The following is a description of a gene set: Any process that modulates the frequency, rate or extent of the directed movement of charged atoms or small charged molecules into, out of or within a cell, or between cells, by means of some agent such as a transporter or pore. studied in species Homo sapiens Human Gene Set: GOBP_REGULATION_OF_MONOATOMIC_ION_TRANSPORT, and this is the list of marker genes: CRBN (NCBI Gene Id 51185), G6PD, TACR2, CALHM1, GRP, P2RX2, CD4, ATP1A2, RGS9, VDAC1, EFHB (EF-hand domain family member B), PDPK1, EPO, STIMATE, ATP8B1, PPP3R1, SLC31A2, LIME1, MLLT6, AGT, SCN2B (sodium voltage-gated channel beta subunit 2), HOMER3 (homer scaffold protein 3), MYLK, CACNG6, KCNJ10, TESC, NTSR1, SLMAP, F2RL3, BCL2, TRPC3, MIR133A1, UTRN, SPTBN4, SCN5A, AKAP5, KCNS1, STC2 (NCBI Gene Id 8614), CACNB4, DPP6, SCN10A, LCN2, AFG3L2, ATP1B3, MS4A1, TREM2, PHB2, WNK3, P2RX3 (NCBI Gene Id 5024), TRPC6, ADCYAP1R1, RAB11B, GRIN2C, KCNAB2, KCNJ15, HOMER1, CD19, RGS4, KCNN2, CRHR1, CASK, KCNJ9, ADORA2A, PACSIN3, NIPSNAP2, ABCC9, BDKRB1, SARAF, COMMD1, TMEM38A, MIR29B1, BAK1, XCL1, HPCA, KCNJ12, CD63, GPER1, KCNJ3, RYR2, SESTD1, CXCR3, ATG5, ATP1A1, KCNE5, PRSS8, CAB39, TMX1, CAMK2G, KCNS3, WNK4, ABCB1, TMC2, SNTA1, GCK, FXYD4, ASIC2, KCNIP3, FKBP1A, LGALS3, GRIN2A, ISL1, PKD2, REM1, CNTN1, OSR1, CCL2, MIR424, MRLN, KCNQ1, GCG, MIR448, KCNK16, SEMG1, SELENON, NOS1, EDN3, CHD7, BEST1, SRI, CACNG1, MMP9, FXYD6, CAMK2B, HAP1, KCNRG, CA2, P2RX5, CYBA, HOMER2, DPP10, HFE, SCN4B, TRPC1, THY1, STIM2, SPINK1, WFS1, TRDN, HTR1B, BIN1, AKT1, CCL5, PML, TCIRG1, GNB2, OXSR1, FKBP1B (NCBI Gene Id 2281), MCHR1, TRIM27, SLC30A1, ABL1, GRM6, HTT, KEL, EPPIN, LRRC55, CBARP, IL16, NKAIN2, LEP, MIR26A1, FXYD5, SCN1B, BEST3, MIR208B, KCNE1, CCL4, LRRC38, PRKCE, TMEM38B, YWHAQ, DLG1, JPH2, CNKSR3, CTSS, CREB3 (NCBI Gene Id 10488), GPD1L, RCVRN, FMR1, TOR2A, GRIN2B, KCNJ1, SNCA, PLPP4, NKX2-5, KCNJ16, PCSK9, ACTN4, F2, PTPN3 (NCBI Gene Id 5774), P2RY6, MIR1-1, UBQLN1, TRPA1, ANK3, KCNAB3 (potassium voltage-gated channel subfamily A regulatory beta subunit 3), EPB41 (erythrocyte membrane protein band 4.1), SERPINE2, CX3CL1, GPR35, SPG11, YWHAE, CRH, LYN, CALM1, MIR208A, FXYD7 (FXYD domain containing ion transport regulator 7), MIR21, GOPC, PDE4B, LRRC26, VAMP2, TSPO, P2RX4, STIM1, DRD2, B2M, GRIN1, KCNS2, ATP2B1, MIR34A, HTR1A, MIR192 (NCBI Gene Id 406967), TRPV3, HTR2A, KCNN4, ATPSCKMT (NCBI Gene Id 134145), TMC1, CRACR2A, UCP2, GRIN3B, AMIGO1, COX17, OPRK1, F2R, PPP3CC, BPIFA1, APP (amyloid beta precursor protein), CA7, NOS3, KCNJ13, PRKG2, PRKD1, EDN1, ADRA2A, PDZK1, STAC2, JPH3, KCNJ11, CLDN10, PTK2B, KCNH2, CAMK2A, DMD, NPSR1, PPP3R2, FXYD1, ITGB3, PTPN6, P2RY12, FYN (FYN proto-oncogene, Src family tyrosine kinase), MIR103A1, PRNP, UCN, KCNJ2, GABRE (NCBI Gene Id 2564), WNK1, FFAR1, SPHK2, SLC8A1, PLN, KCNAB1, CHRM1, SLC30A6, YWHAH, CCL3 (C-C motif chemokine ligand 3), PPIF (NCBI Gene Id 10105), KCNIP2, TRPV2, MIR200C, TLR9, PRKACA, CORO1A, NKAIN4, KCNJ5, KCNG1, AKAP7, CAV1, ANO6, ACTN2, P2RX1, LILRB1, LPAR3, PDGFB, CXCL12 (NCBI Gene Id 6387), HEPH, SLC6A4, CXCL10, MIR93, CACNB1, DIAPH1, JPH4, NGF, CASQ2, PDE4D, KCNF1, MIR30D, FXYD3, PXK, GALR2, ABCC8, KCNG4, KCNJ18, PER1, LILRA2, FHL1, KCNC1, NEDD4L, JPH1, ATP4A, SCN3B, LILRB2, LILRA5, PLA2G1B, FCRL3, TMSB4X, STAC, GRIA1, TMBIM6, HAMP, HES1, STRIT1, STOM, CALM2, MIR24-1, RANGRF, ATP2B4 (NCBI Gene Id 54594), WWP2, PKP2, IL13, CLIC2, ORAI1, CACNA2D1, ISCU, SIK1, SLC8B1, INPP5K, DRD1, TCAF1 (TRPM8 channel associated factor 1), IFNG, ATP2A1, PDGFRB, STK39, CAMK2D, KCNIP4, SLC26A5, HRC, PPP3CB, ASPH, CXCL9, KCNG2, CACNA1C (NCBI Gene Id 775), CALCA, KCNJ4, FLNA, GRIN2D, CACNA1F (calcium voltage-gated channel subunit alpha1 F), EGF (epidermal growth factor), KCNG3, GNAI2, ATP2C2, FXYD6P3, CAV3, NHERF1 (NHERF family PDZ scaffold protein 1), CACNB3, MIR499A, VMP1, CCR1, CASR, KCNE3, MIR328, GNB5, NPPA, ADORA1, SLN, KCNJ14, NKAIN1, P2RX7, MIR212, SUMO1, MCUB, GRAMD2A, KCNJ6, CALM3, UBR3, AHNAK, PSEN2, CACNB2, DHRS7C, ADRB2, ATF4, CACNA1D, STC1, SPG7, LRRC52, NEDD4, ANK2, ATP1B2, CD84, P2RY1, UBASH3B, CXCL11, KCNC2, WNK2, GSTM2, METTL21C, CASQ1, DRD3, FGF12, APLNR, PLCG1, NKAIN3, AHCYL1, OPRD1, BAX, KCNE2, EDNRA, CEMIP, STAC3, TCAF2, MIR210, CFTR, FGF13, FXYD2, AKAP6, LACRT, HCRT (NCBI Gene Id 3060), KCNJ8, GAL, PPP3CA, KIF5B, TSPAN13, GSTO1, NOS1AP, PIK3CG, KCNIP1, DMPK (NCBI Gene Id 60405), TGFB1, CTNNB1, CAPN3, ATP1B1, CHP1